Given this list of marker genes DPEP1 (NCBI Gene Id 1800), GCLC, OPLAH, GSS, GGCT, GGT1, here is a description of the gene set: Human Gene Set: WP_GAMMAGLUTAMYL_CYCLE_FOR_THE_BIOSYNTHESIS_AND_DEGRADATION_OF_GLUTATHIONE_INCLUDING_DISEASES species: Homo sapiens Gamma-glutamyl cycle for the biosynthesis and degradation of glutathione, including diseases